Given this list of marker genes Men1, Id3 (inhibitor of DNA binding 3), Cited1, Tnf, Mir214, Sox2, Ipo7, Mir205, Dlk1, Notch1 (NCBI Gene Id 68125), Mir30c-2, Smad3, Smad6, Hand2, Ostn, Bambi, Hoxa2, Erfe, Mir23a, Limd1, Crim1, Hdac8, Fgf23, Lrp5, Tnn, Sema4d, Sfrp1, Fndc3b, Mir137, Hdac7, Vegfc (vascular endothelial growth factor C), Trpm4, Mir133a-1, Nog, Fgfr1, Chrd, Noct, Ranbp3l, Ski, Ucma, Ptch1, Gsk3b, Mir135a-1, Sox9, Tob1, Mir217, Nbr1, Riox1, Areg, Tnfaip6, Mir338, Mir133a-2, Cdk6, Nfatc1, Id2, Ahr, Id1, Tmem64, Grem1, Mir30c-1, Tmem53, Twsg1, Rorb, Twist1, Hdac4, Mir204, Hdac5, Twist2, Igfbp5, Zfp932, Axin2, Pparg, here is a description of the gene set: studied in species Mus musculus Any process that stops, prevents, or reduces the frequency, rate or extent of osteoblast differentiation. Mouse Gene Set: GOBP_NEGATIVE_REGULATION_OF_OSTEOBLAST_DIFFERENTIATION